Given this list of marker genes HTATIP2, GIPC2, DEFB1, COL4A2, NIBAN1, CTSL, SLC24A3, NDRG1, SLPI, SGK1, APCS, VNN3P, ABHD2, IGFBP2, HLA-DQA1, CBR1, FABP2, FABP4, QPCT, TAGLN2, PEX11A, CD63, CSTB, CIDEC, MFGE8, GPX4, KRT23, LGALS3BP, HDAC1, TBC1D8, RAD51B, SPON2, SPRR1A, CD74, TM4SF4, ANXA5, UAP1L1, ANXA2, CD24, TOX, KRT8, RGS2, IGFBP1, PLAT, IMPACT, PLIN2, SLC20A1, LCN2, LPL, HOXC6, MT2A, RAP1GAP, SORBS2, EHHADH, SLC16A1, RPL12, CBR3, RPL36, ETS2, EDN1, NQO1, PLSCR1, LY6E, CTSE, PALMD, here is a description of the gene set: Genes up-regulated in hepatocellular carcinoma of ACOX1 knockout mice. Human Gene Set: LEE_LIVER_CANCER_ACOX1_UP species: Homo sapiens from publication Lee JS, Chu IS, Mikaelyan A, Calvisi DF, Heo J, Reddy JK, Thorgeirsson SS (PMID 15565109) Genetically modified mice have been extensively used for analyzing the molecular events that occur during tumor development. In many, if not all, cases, however, it is uncertain to what extent the mouse models reproduce features observed in the corresponding human conditions. This is due largely to lack of precise methods for direct and comprehensive comparison at the molecular level of the mouse and human tumors. Here we use global gene expression patterns of 68 hepatocellular carcinomas (HCCs) from seven different mouse models and 91 human HCCs from predefined subclasses to obtain direct comparison of the molecular features of mouse and human HCCs. Gene expression patterns in HCCs from Myc, E2f1 and Myc E2f1 transgenic mice were most similar to those of the better survival group of human HCCs, whereas the expression patterns in HCCs from Myc Tgfa transgenic mice and in diethylnitrosamine-induced mouse HCCs were most similar to those of the poorer survival group of human HCCs. Gene expression patterns in HCCs from Acox1(-/-) mice and in ciprofibrate-induced HCCs were least similar to those observed in human HCCs. We conclude that our approach can effectively identify appropriate mouse models to study human cancers.